Given this list of marker genes PTRHD1, SPTLC2, PRDX3, CNTNAP1, PDK3, FXN, RRM2B, VAMP1, HPDL, MPZ, SPG7, MORC2, NDRG1, EBP, VCP, CACNA1S, MTMR2, RAB7A, RETREG1, WNK1, SIGMAR1, ATL3, SBF2, MEGF10, LYST, COL6A1, VPS13A, SCP2, SH3TC2, DEGS1, LRSAM1, SLC25A15, SOX10 (NCBI Gene Id 8223), SPTAN1, HSD17B4, NPTX1, ALS2, POLG, CEP126, HYCC1, CADM3, FBLN5, DHX16, BSCL2, HIKESHI, ERCC8, NFASC, GABRA3, MFN2, ATXN1, NTRK1, MOGS, ITPR1, IGHMBP2, CTDP1, GARS1, SETX, MTRFR, TBC1D24 (NCBI Gene Id 57465), ERCC6, HSPB1, TRPV4, MFF, MED25, TRIM2, PRPS1, ARSA, LTBP3 (latent transforming growth factor beta binding protein 3), RFC1, ARHGEF10, TPI1, DCAF8, COMP, FLNC, IDUA, PLEKHG5, FBXO38, NGLY1, SUCLA2, SAMD9L, ERCC4, PSAP, FIG4, SPG21, FGD4, PMP2 (NCBI Gene Id 5375), ITPR3, ATXN10, LITAF, ERCC3, CPLANE1, PNKP, UQCRC1, KIF1A, EMILIN1, SBF1, SEMA6B, ATP11A, MPV17, SLC12A6, PRX, NHLRC1, YME1L1, TBCK, TBC1D20, ABCD1, LMNB1, MATR3, DNM2, GJC2, PLP1, OTOF, TYMP, ABHD12, GJB1, KIF1B, SLC5A7, HSPB8, SAMD12, GDAP1, DNAJC3, FLVCR1, NMNAT1, KARS1, ARHGEF2, NALCN, ATP7B, NEU1, LMNA, PMP22, CYP27A1, EDNRB, AIFM1, RIPOR2, YEATS2, EGR2, UBA1, AARS1, GFM2, DNAJB6, MARCHF6, SUMF1, YARS1, REEP1, STARD7, ATL1, SPTBN4, JPH1, TTPA, MYH3, HINT1, DHH, EPM2A, CHCHD10, SYT2, LAMA2, SORD, CCT5, MYH14, PTRH2, SACS, PNPT1, PEX6, KCNJ18, TIMM8A, TFG, SCN9A, PLA2G6, DIAPH3, NOTCH2NLC, TDP1, FBN1, RNF170, HK1 (NCBI Gene Id 59333), SNAP29, SPTLC1, GALC, LIG3, RAI1, NEFL, OPA1, here is a description of the gene set: Abnormal peripheral nervous system physiology Any functional abnormality of the part of the nervous system that consists of the nerves and ganglia outside of the brain and spinal cord. Human Gene Set: HP_ABNORMAL_PERIPHERAL_NERVOUS_SYSTEM_PHYSIOLOGY species: Homo sapiens